The following is a description of a gene set: Human Gene Set: GOBP_REGULATION_OF_INFLAMMATORY_RESPONSE Any process that modulates the frequency, rate or extent of the inflammatory response, the immediate defensive reaction (by vertebrate tissue) to infection or injury caused by chemical or physical agents. species: Homo sapiens, and this is the list of marker genes: SBNO1, IL2, MIR302E, GGT1, IER3, CLOCK, CAMK2N1, ADIPOQ, LRRK2, IL12B, C1QTNF12, MIR26A1, TGFB1, HYAL2, DROSHA, NR1H3, CASP12, PLA2G2D, LGALS1, GSTP1, GNAS (NCBI Gene Id 82944), FOXF1, SYK, MIR657, SUCNR1, NR1H4, IL1B, EDNRB, MIR4286, DUOXA1, DDT, NLRC3, ESR1, OSM, MCPH1, PIK3AP1, NOD2, ARNT, IL17RB, APP, TLR3, OSMR, MVK, ZBP1, AHR, FUT7, SAA1, NPY5R, NUPR1, MIR19B1, CD200R1L, MIR138-1, PIK3CG, ZDHHC5, MIR15A, TNFAIP6, ELANE, TREX1, TNFRSF1A, PPARD, CCR7, BIRC3, FGR, NAIP, VAMP8, FFAR3, GPRC5B, FANCD2, IL18, AOAH, CD200R1 (CD200 receptor 1), DUSP10, MIR19A, IL6, CD200, OTULIN, PRKCD, SELE, MACIR, CELF1, MIR199A1, IL20RB, SNX4, HLA-DRB1, IL22, ETS1, CALHM2, NLRP4, IL1RL2, STAT5B, TNFAIP3, CDH5, MIR128-1, DAGLA, IL2RA (interleukin 2 receptor subunit alpha), FFAR4, NFKBIA, ELF4, PYDC2, IFI35, MIR181A2, MIR187, SMPDL3B, RABGEF1, ZP3, VAMP7, IL20, ARMH4, ADA, MIR126, PSMA6 (proteasome 20S subunit alpha 6), USP18, NR1D1, GPR4, PLA2G7, MIR361, FFAR2, WNT5A, GPR31, GBP3, TAFA3, UACA, GPER1, LRFN5, FANCA, DEFB114, ADAM8, EXTL3, DNASE1, PSMA1, NDFIP1 (Nedd4 family interacting protein 1), NEAT1, TNC, RB1, BRD4, SHPK, GGT3P, TLR2, MIR146A, IL17RA, MIR181B1, SOCS3, SPHK1, APOE, CASP1, FEM1A, METRNL, MEFV, NLRP9, TNFRSF1B, NCF1, SCGB1A1, SRC, IL15, CCL3, MGST2, SETD4, F12 (NCBI Gene Id 58992), MAPK14, APCS, MIR105-1, IL17A, IL1RL1, MIR590 (microRNA 590), ADORA2B, ENPP3, RPS19, RHBDF2, MIR221, S100A8, BST1, MIR142, PTGER3, STK39, TMSB4X (NCBI Gene Id 7114), FCGR1A, ASH1L (ASH1 like histone lysine methyltransferase), CTSC, VAMP3, NINJ1 (NCBI Gene Id 4814), BCR, BCL6, SIRPA, ALOX15, CMA1, MIR30C2, NLRP7, NR5A2 (nuclear receptor subfamily 5 group A member 2), CYP19A1, MIR223, GPR17, CD47, PTGES, FXR1 (FMR1 autosomal homolog 1), TNF, ADORA2A, PDCD4, MIR15B, IL22RA2, LBP, NPY, CST7, SELENOS, MIR149, NT5E, AREL1 (NCBI Gene Id 9870), MAP3K8, MIR21, SIGLEC10, MIR31, CYLD, PTPN2, RELA, TLR6, MMP9 (matrix metallopeptidase 9), GBP5, SLC39A8, MIR181C, GSDMD, GRN, FOXP1, TNFSF18, MIR3909, FCGR2B, RHBDD3, MDK (NCBI Gene Id 4192), FNDC4, FPR2, BCL6B, TNIP1, MYD88, LTA, KARS1, PPARG, PTPN6, SEMA7A, IDO1, C2CD4B, PTGER4, CASP3, SETD6, MIR144, REG3A, MIR205, IL22RA1, CCR2, S100A9, MGLL, MIR920, YES1, IGF1, PBK, CCL1, NKG7 (NCBI Gene Id 4818), DUOXA2, STING1, MIR16-1, TNFSF4, GGT2P, ABHD12, ACOD1, SMAD3, PGLYRP2, TLR7, TRIM45, CASP5, TRIM65, XCL1, NAPEPLD, TEK (TEK receptor tyrosine kinase), MIR204, STAT3, SBNO2, MMP26, GPSM3, DNASE1L3, MIR92A1, NR1H2, IL13, SNCA, SLAMF8, CD28 (CD28 molecule), BTK, LRRC19, IL10RA, FAM76B, NMI, IL4, IRGM, HGF, NLRP11, IL6ST, IL33, IL21, MMP8, FCER1G, FOXP3, KRT1, TAC1, PPP1R13L, IL10, INS, UFL1, MAPK7, CEBPB, XIAP, KLF4, FURIN, GIT1, MIR206, TLR9, GATA3, PLK2 (polo like kinase 2), PLA2G10, PLCG2, MIR195, AGT, VAMP2, MIR766 (microRNA 766), PSMB4, C3, KLKB1, PDE2A (phosphodiesterase 2A), TSLP, MIR141, TTBK1, GBA1, TRADD, ISL1, ALOX5, CREB3L3, IL37, JAK2, TREM2, AGTR1, TYRO3, CD81, HLA-E, NLRP10, MIR20A, CCL24, SYT11, NLRP14, FYN, IL1R1, VPS35, ACE2, GHSR, NLRP13, CASP4, RIPK1, STAP1, LPL, NR1D2, WFDC1, GPX1, NLRX1, MIR6869, MMP3, ABCC1, MFHAS1, MAS1 (MAS1 proto-oncogene, G protein-coupled receptor), C1QTNF3, IRF3, MKRN2 (makorin ring finger protein 2), FBXL2, CEBPA, RORA, AIM2, IL23A, ACP5, C2CD4A, PLA2G2A, NLRP5, GHRL, TRPV4 (NCBI Gene Id 8098), SERPINE1, AKNA, PTGS2, LGALS2, CXCL17, BAP1, PTGIS, SHARPIN, STAT5A, PPARA, LACC1, SOCS5, PLA2G3, TNFAIP8L2, GBP1, ADORA1, NFKB1, MAPK13, DSG2, GBP2, NFKBIZ, SPATA2, MIR488, NLRP6, NLRP8, TNFRSF11A, IFNG, GPS2, NLRP2, S100A12, CCL5, RICTOR, MIR222, MIR145, NFE2L1, NLRP1, PARK7, PLCG1, IL16, ADAMTS12, AHSG, SNX6, PGLYRP1, PTPRC, DAGLB, NLRC4, LETMD1, BIRC2, CLEC12A, SPN, LDLR, CCN4, IFI16, HCK, NLRP3, TLR4, NLRP12, DHX9, MIR22, LPCAT3, AGER, APOA1, LYN, PROC, SOD1, ANXA1, TNFSF11, HTR2A, PYCARD, ZDHHC9, CX3CL1, FABP4, MIRLET7G, CCN3, LILRA5